The following is a description of a gene set: Mouse Gene Set: GOBP_REGULATION_OF_NEUROBLAST_PROLIFERATION Any process that modulates the frequency, rate or extent of neuroblast proliferation. studied in species Mus musculus, and this is the list of marker genes: Disc1, Shh, Lhx5, Ctnna1, Bex1, Vegfa, Fgf2, Kifap3, Gli3, Nf1, Kctd11, Dct, Hif1a, Notch1, Cd24a, Skor2, Zfp335, Fgfr3, Cdon, Sox10, Mapk8 (NCBI Gene Id 26419), Bdnf, Smo (smoothened, frizzled class receptor), Sox2, Lrrk2 (leucine-rich repeat kinase 2), Pax6, Prl2c2, Trp53, Ctf2, Six3, Btg2, Cip2a, Itgb1, Nr2e1, Cx3cr1 (NCBI Gene Id 13051), Ptn, Foxg1 (forkhead box G1), Wdr62, Tgfb1, Dmrta2, Id4, Ctnnb1, Vsx2, Prox1, Otp, Kdm1a, Sall1, Vegfc, Aspm, Tafa1, Smarcd3, Gata2, Drd2, Cx3cl1, Fzd3, Vax1